The following is a description of a gene set: species: Homo sapiens This pathway serves as collection of reactions categorized as SLC-mediated transport of inorganic anions Reactome Pathway: SLC-mediated transport of inorganic anions part of: SLC-mediated transmembrane transport, and this is the list of marker genes: SLC20A2, SLC5A8, SLC12A1, SLC26A7, SLC12A4, SLC26A6, SLC4A7, SLC26A9, SLC13A1, SLC4A10, SLC17A1, SLC5A5, SLC4A5 (solute carrier family 4 member 5), SLC13A4, SLC12A7, SLC4A1, SLC20A1, SLC34A2, SLC4A9, SLC26A2, SLC34A3, SLC26A3, SLC26A11, AHCYL2, SLC4A4, SLC12A3, SLC12A6, SLC26A4, SLC4A8, SLC12A2, SLC12A5, SLC4A3, SLC34A1, SLC4A2, SLC26A1